Given this list of marker genes FAM107B, TK2, CD2 (CD2 molecule), MCL1, CD74, SLC25A53, UBP1, SMIM14, FCRLA, IL4R (NCBI Gene Id 3566), CLK1 (NCBI Gene Id 1195), RIOK3, RBM39, SCD (NCBI Gene Id 6319), NEAT1, TUT7, ATP6V0B, TMEM71, MYL12B (myosin light chain 12B), CAPN1 (calpain 1), UBE2H, CD79B, RHOQ (ras homolog family member Q), RALGPS2, HLA-B, CYTIP (NCBI Gene Id 9595), CD22, TRAF3, ADCY7, TANK, LY86, JARID2, GNS, AKIRIN1, BTG1, PTPRC (NCBI Gene Id 5788), S1PR1, IL10RA, CD72, DTX1, UBLCP1, LYN, LPGAT1, PNRC2, ZFP14, IGKC, ZFP36, BIRC3, IAH1, TMEM50B, FCGR2B, MS4A1, NBR1, NFKB1, LSP1, ATP6AP1, PDE7A, PTK2B, CCNDBP1, GUCD1, BLK, FBXO11, ABLIM1, KLF2, CASP9, FAM3C, TRAF5, ERO1B, ERP29, BTG2, DIP2B, CNR2, TSNAX, TIRAP, SAT1, RGS14, GPCPD1, CRYBG1, SAMHD1, NFKBIZ, here is a description of the gene set: The Emu-myc transgenic mouse has provided a valuable model for the study of B-cell lymphoma. Making use of gene expression analysis and, in particular, expression signatures of cell signaling pathway activation, we now show that several forms of B lymphoma can be identified in the Emu-myc mice associated with time of tumor onset. Furthermore, one form of Emu-myc tumor with pre-B character is shown to resemble human Burkitt lymphoma, whereas others exhibit more differentiated B-cell characteristics and show similarity with human diffuse large B-cell lymphoma in the pattern of gene expression, as well as oncogenic pathway activation. Importantly, we show that signatures of oncogenic pathway activity provide further dissection of the spectrum of diffuse large B-cell lymphoma, identifying a subset of patients who have very poor prognosis and could benefit from more aggressive or novel therapeutic strategies. Taken together, these studies provide insight into the complexity of the oncogenic process and a novel strategy for dissecting the heterogeneity of B lymphoma. Human Gene Set: MORI_PRE_BI_LYMPHOCYTE_DN species: Mus musculus from publication Mori S, Rempel RE, Chang JT, Yao G, Lagoo AS, Potti A, Bild A, Nevins JR (PMID 18922927) Down-regulated genes in the B lymphocyte developmental signature, based on expression profiling of lymphomas from the Emu-myc transgenic mice: the Pre-BI stage.